The following is a description of a gene set: Anisopoikilocytosis Human Gene Set: HP_ANISOPOIKILOCYTOSIS A type of poikilocytosis characterized by the presence in the blood of erythrocytes of varying sizes and abnormal shapes. species: Homo sapiens, and this is the list of marker genes: STEAP3, AMN, HBB, CLPB (NCBI Gene Id 81570), SC5D, CRIPT, KCNN4, MPIG6B, CAD, CUBN